Given this list of marker genes CEBPA, ALCAM, NR1D1, MCM10, CPT1A, PSEN2, ADH4, ONECUT1, NPC1, CRY1, IDI1, ANP32A, MAPK14, THRAP3, PPDPF, TUBB, DHRS3, H2BC1, HNRNPAB (heterogeneous nuclear ribonucleoprotein A/B), CHKA, UBAP2L, AQP9 (aquaporin 9), DAZAP2, CHORDC1, CYP8B1, SLC29A1, USP2, LGALS9, IFT46, LMO7, POR, UBXN1, OGA, IFITM3, SERPINF2, SLC11A2 (solute carrier family 11 member 2), CES1, CD47, PPARA, CYP2A6, LITAF, RCL1, KLF9, HSPA4, ID2 (NCBI Gene Id 3398), DNAJA1, LSR, ZNF644, ELOVL5, ATF5, HTATIP2, CD9, SQSTM1, FBXO8 (NCBI Gene Id 26269), STBD1, IRF6, TARS1 (threonyl-tRNA synthetase 1), KAT2B (lysine acetyltransferase 2B), MAP2K3, FASN, PNP, CYB5B, SLC37A4 (solute carrier family 37 member 4), H1-2, HSPA8, AVPR1A, CEBPB, INCA1, TMEM150A, ETFBKMT, PTP4A1, RIPOR2, CRIP2, UBR3, S100A10, PCSK4, UPP2, GABARAPL1, MYORG, TUBA3D, NR1D2, COL4A1, GALT (galactose-1-phosphate uridylyltransferase), BRI3, ABCB4, PLA2G12A, NFIL3, HSP90AA1 (heat shock protein 90 alpha family class A member 1), CHP1, RBPMS, FDX1, ATL2, ERBB3, PER2, FBXO21, HAL (histidine ammonia-lyase), FERMT2, TSPAN4, GLDC, HES6, BTG1, ALAS1, RBM3, CREBRF, TNFRSF1B, SLC25A47, CCL15, GPCPD1, GLO1, H6PD, ST3GAL5, DNAJB11, BHLHE40, IRF9, DYNLL1, HMGCR, PNPLA2, ACOT2 (acyl-CoA thioesterase 2), PPP1R3C, HMGCS1, STMP1, PNKD, BMAL1, IL4R, DHCR7, HMGB3, CYP7A1, CKS2, COL18A1, F2R, MKNK2, ATXN2, FKBP4, CLDN1, MESD, AK4 (NCBI Gene Id 387851), AQP8, TSC22D1, TUBB2A, RBMS1, GNE, HSD3B1, PDIA4, C6orf89, LPIN2, FDPS, FOXA3, SLC2A2, ASL, HERPUD1, SPATA13, NOCT, LBHD1, ST3GAL1, FGF1, ETHE1, RORC, TRIP6, TFPI2 (NCBI Gene Id 7980), TLE1, APOA5, CNOT1, CHD4, BNIP3, AK2, NDRG1, GCLC, LONP2, HSPH1, NHERF1 (NHERF family PDZ scaffold protein 1), TUBA1A, ELOVL6, here is a description of the gene set: from publication Ueda HR, Chen W, Minami Y, Honma S, Honma K, Iino M, Hashimoto S (PMID 15273285) Detection of individual body time (BT) via a single-time-point assay has been a longstanding unfulfilled dream in medicine, because BT information can be exploited to maximize potency and minimize toxicity during drug administration and thus will enable highly optimized medication. To achieve this dream, we created a molecular timetable composed of >100 time-indicating genes, whose gene expression levels can represent internal BT. Here we describe a robust method called the molecular-timetable method for BT detection from a single-time-point expression profile. The power of this method is demonstrated by the sensitive and accurate detection of BT and the sensitive diagnosis of rhythm disorders. These results demonstrate the feasibility of BT detection based on single-time-point sampling, suggest the potential for expression-based diagnosis of rhythm disorders, and may translate functional genomics into chronotherapy and personalized medicine. Molecular timetable composed of 162 time-indicating genes (182 probes) in the peripheral (liver) clock. studied in species Mus musculus Human Gene Set: UEDA_PERIFERAL_CLOCK